The following is a description of a gene set: studied in species Mus musculus Mouse Gene Set: GOBP_FC_GAMMA_RECEPTOR_SIGNALING_PATHWAY The series of molecular signals initiated by the binding of the Fc portion of immunoglobulin G (IgG) to an Fc-gamma receptor on the surface of a target cell, and ending with the regulation of a downstream cellular process, e.g. transcription. The Fc portion of an immunoglobulin is its C-terminal constant region., and this is the list of marker genes: Appl2, Appl1, Fcer1g, Oscar, Nos2, Clec4d, Lck, Fcgr1, Clec4e, Fcgr3, Fcgr4, Cd247, Fcer2a, Myo1g